Given this list of marker genes SH2B3, UBE3A, LPIN1, SLC44A5, VPS13A, MSI2, ZFX, SLC35D3 (NCBI Gene Id 387073), AMER3, CSE1L, AIMP1, GALK2, SNX13, DOCK5, SOX4, ARHGEF38, CAPS2, DENND6A (NCBI Gene Id 201627), JMY, BMI1, GRAMD2B, MYLK, TAC3, C14orf132, LHFPL2, SRBD1, SRPK1, ADRA2B, CLCA4, HES5, SSX2IP, KIAA0825, NLRP11, INO80D, ASAP3, C5orf15, PRPS2, KCTD15, SLITRK5, NPR3, SMC1A, TOGARAM1, CACHD1, LRIG3, PEX5L, APRG1, ANKRD34B, LSM14A (LSM14A mRNA processing body assembly factor), PMP2, SLC39A8, H2AX, MYB, TEKT3 (NCBI Gene Id 64518), KLF12, MINAR1, SPTSSB, ENKUR, ENGASE, SLC24A4, COMMD3-BMI1, DACH1, BBS7, CYLD, ZNF519, TRNT1, AGPS, KCNC2, MFSD14B, HTR2A, RDX, SSR3 (signal sequence receptor subunit 3), ATP5MC3, LPGAT1, CDC27, SENP7, SH2D1A, RCN1, CYP7A1, THUMPD1, CLEC2D, PEX12, FOXC1, CD164, KIF1C, KLHDC1 (kelch domain containing 1), SRSF2, SYAP1, STK26, RBM41, UBAP1, FRMD6, TNNI2, SNRPF, FPGT, SLC5A3, PAN3, STEAP2 (NCBI Gene Id 50630, STEAP2 metalloreductase), DCDC2, ABCC2, ZFYVE9, MMP13, GRIA4, EML1, PXK, TRIM65, TBR1, PRDX3, MCU (mitochondrial calcium uniporter), PLXNB1, KRR1, PCOLCE2, KCND2, LPAR1, ATL2, PNN, BAZ1A, DNAJC6, CHST9, ODAD2, CT45A9, PPP6R3, NR4A3 (nuclear receptor subfamily 4 group A member 3), PEG10, JUN, DRAM2, PINX1, RIPK2, NEXMIF, RIMKLB, MAGEB6, CNP, HDAC9, BLID, PLP1, CT45A5, MEF2C, IRF2BPL, CT45A10, FUT9, MARK1, NFIL3, EIF3M, JADE3, ALX1, DYNC1I2, PAK3, RAB27B, PTPN4 (protein tyrosine phosphatase non-receptor type 4), ZNF471, UBE4B, MAP4, TFAM, here is a description of the gene set: from publication Chen Y, Wang X (PMID 31504780) studied in species Homo sapiens Human Gene Set: MIR501_5P Genes predicted to be targets of miRBase v22 microRNA hsa-miR-501-5p in miRDB v6.0 with MirTarget v4 prediction scores > 80 (high confidence targets).